Given this list of marker genes UROD, AVPR1B, COX10, TIMM17A, N4BP2L2, PDE6B, BCAT2, ZNF134 (zinc finger protein 134), SLC2A4, CENPI, MVK, NQO2, FCGR2A, SMARCD1, MPP2, CCR9, MADD, CCL2, FUT2, ABRAXAS2, AQP7, GSTZ1, NDUFA1, IKBKE, BNIP1, TTC1, MYH7, CHIC1, LPAR4, TMEM106A (transmembrane protein 106A), CHMP1A, RING1, KRT83, GHRHR, CD8B, DPF2, ASMT, SLC18A1, ZNF137P, CSTF3, GRM4, APOC3, HTT, IGKV7-3, NCAPD3, RABGGTA, ZNF8, HTR1E, DRD1, BDH1, PLG (NCBI Gene Id 90749, plasminogen), AANAT, ELK4, ATP12A (NCBI Gene Id 479), KRT31, FEV, KRT35, VPS72, AAMP, SUPT4H1, GH2, NFIC, ADCYAP1, CHRM5, TAF1, FABP3, HMGXB3 (HMG-box containing 3), PMS2P11, IRF5, DGCR6, DRG2, PTPN5, MAPK3, FANCC, MYCL, SDHC, PTPRU, HMGA2, here is a description of the gene set: Neighborhood of BNIP1 BCL2/adenovirus E1B 19kDa interacting protein 1 in the GCM expression compendium Human Gene Set: GCM_BNIP1 studied in species Homo sapiens Neighborhood of BNIP1